Given this list of marker genes AICDA, CDADC1, APOBEC3G, DCTD, APOBEC3C, CDA, here is a description of the gene set: species: Homo sapiens The chemical reactions and pathways involving cytidine, cytosine riboside, a widely distributed nucleoside. Human Gene Set: GOBP_CYTIDINE_METABOLIC_PROCESS